Given this list of marker genes Mir200b, Mir9-2 (microRNA 9-2), Lhx9 (NCBI Gene Id 98737), Mir376a (NCBI Gene Id 723855), Evx1 (NCBI Gene Id 14028), Mir9-3, Mir9-1, Dlx5, Mir200a, Mir200c, here is a description of the gene set: Mouse Gene Set: GOBP_INTERNEURON_AXON_GUIDANCE studied in species Mus musculus The process in which the migration of an axon growth cone of an interneuron is directed to a specific target site in response to a combination of attractive and repulsive cues. An interneuron is any neuron which is not motor or sensory. Interneurons may also refer to neurons whose axons remain within a particular brain region, as contrasted with projection neurons which have axons projecting to other brain regions.